The following is a description of a gene set: Genes in the cancer module 264. species: Homo sapiens Human Gene Set: MODULE_264, and this is the list of marker genes: AP2S1, AP3S1, SEC31A, LRP8, ARCN1, AP1S2, AP2M1, HPCAL1, AP2A1, HPCA, SEC24D